The following is a description of a gene set: studied in species Homo sapiens Human Gene Set: WP_CANONICAL_AND_NONCANONICAL_TGFB_SIGNALING Canonical and non-canonical TGF-B signaling, and this is the list of marker genes: MAPK9, MAPK14, BMPR2, BMPR1A, LOXL4, LOXL1, MAPK8, BMP1, TGFB1, LOX, GREM1, TGFBR2, SMAD4 (SMAD family member 4), LOXL2, SMAD2, TGFBR1, SMAD3